The following is a description of a gene set: Any process that modulates the frequency, rate or extent of protein localization to cilium. studied in species Homo sapiens Human Gene Set: GOBP_REGULATION_OF_PROTEIN_LOCALIZATION_TO_CILIUM, and this is the list of marker genes: EFCAB7, CCDC88A, GDI2, CCDC66, CROCC, DZIP1 (NCBI Gene Id 22873), LZTFL1, GAS8, INPP5E, ENTR1, GSK3B